Given this list of marker genes VDAC2, BCL2, MUC1, PRKG1, SOD2, MAPK14, VDAC1, SLC25A4, KNG1, GPX4, TSPO, MCL1, TXN, WDTC1, here is a description of the gene set: Proteins acting on mitochondria to prevent membrane permeabilization. from publication Galluzzi L, Larochette N, Zamzami N, Kroemer G (PMID 16892093) Human Gene Set: GALLUZZI_PREVENT_MITOCHONDIAL_PERMEABILIZATION studied in species Homo sapiens Mitochondria are vital for cellular bioenergetics and play a central role in determining the point-of-no-return of the apoptotic process. As a consequence, mitochondria exert a dual function in carcinogenesis. Cancer-associated changes in cellular metabolism (the Warburg effect) influence mitochondrial function, and the invalidation of apoptosis is linked to an inhibition of mitochondrial outer membrane permeabilization (MOMP). On theoretical grounds, it is tempting to develop specific therapeutic interventions that target the mitochondrial Achilles' heel, rendering cancer cells metabolically unviable or subverting endogenous MOMP inhibitors. A variety of experimental therapeutic agents can directly target mitochondria, causing apoptosis induction. This applies to a heterogeneous collection of chemically unrelated compounds including positively charged alpha-helical peptides, agents designed to mimic the Bcl-2 homology domain 3 of Bcl-2-like proteins, ampholytic cations, metals and steroid-like compounds. Such MOMP inducers or facilitators can induce apoptosis by themselves (monotherapy) or facilitate apoptosis induction in combination therapies, bypassing chemoresistance against DNA-damaging agents. In addition, it is possible to design molecules that neutralize inhibitor of apoptosis proteins (IAPs) or heat shock protein 70 (HSP70). Such IAP or HSP70 inhibitors can mimic the action of mitochondrion-derived mediators (Smac/DIABLO, that is, second mitochondria-derived activator of caspases/direct inhibitor of apoptosis-binding protein with a low isoelectric point, in the case of IAPs; AIF, that is apoptosis-inducing factor, in the case of HSP70) and exert potent chemosensitizing effects.